Given this list of marker genes Clpb, Trpv1, Daxx, Irak1, Pmp22, Arpp21, Cdkn1a, Hspa1b, Ano1, Hsp90aa1, Hikeshi, Trpa1, Tfec, Stac, Scara5, Rasa3, Il1a, Trpv4, Chordc1, Hsbp1, Pdcd6, Hsbp1l1, Sumo1, Dnajb1, Atxn3, Prkaca, Ywhae, Eif2s1, Pdcl3, St8sia1, Nf1, Vcp (valosin containing protein), Xylt1, Dhx9, Myof, Hmox1, Fgf1, Bag3, Eef1d, Tcim, Slc52a3 (solute carrier protein family 52, member 3), Cetn1 (centrin 1), Mapt, Ptgs2, Dhx36, Hsp90ab1, Hspa8, Lyn, Htra2, Hsf3, Hsf1, Rbbp7 (retinoblastoma binding protein 7, chromatin remodeling factor), Slu7, Zfp976 (zinc finger protein 976), Tpr (translocated promoter region, nuclear basket protein), Ier5, here is a description of the gene set: Mouse Gene Set: GOBP_CELLULAR_RESPONSE_TO_HEAT Any process that results in a change in state or activity of a cell (in terms of movement, secretion, enzyme production, gene expression, etc.) as a result of a heat stimulus, a temperature stimulus above the optimal temperature for that organism. species: Mus musculus